Given this list of marker genes ERCC1, RTEL1, TINF2, SMC6, CCT3, ACTR8, PIF1 (PIF1 5'-to-3' DNA helicase), SLX1A, PINX1, ACTL6A, ATR, USP7, HSP90AA1, PARP3, ERCC4, CCT7, NSMCE2 (NCBI Gene Id 286053), PARN, PML, FBXO4, PRKCQ, SLX4, DCP2, PKIB, POT1, NAT10, NAF1, TCP1, XRCC5, INO80B, DKC1, YLPM1, HNRNPA1 (NCBI Gene Id 780920), YY1, MAPK15, NVL, DHX36, TFPT, SLF2, RUVBL1, SMC5, INO80C, NBN, STN1, EXOSC10, MYC, TERF2IP, UPF1, CTC1, HDAC8, HNRNPD (NCBI Gene Id 548), UCHL5 (NCBI Gene Id 82736), SMG6, LMNA, ATRX, CCT8, TENT4B, NEK2, TERF1, NSMCE3, TP53, XRCC1, CCT2, TNKS, SMG1, MAPK1, CCT6A, ATM, SRC, PPP1R10, MCRS1, CTNNB1, GNL3, ACD, HNRNPC, NFRKB, RAD50, SLX1B, NSMCE1, MAP3K4, AURKB, INO80E, HNRNPA2B1, ACTR5, TEN1, EID3, NABP2, INO80D, CCT5, PNKP, SMG5, SLF1, MRE11, MAP2K7 (NCBI Gene Id 5609), TNKS2, KLF4, TERF2, MAPKAPK5, PARP1, CCT4, NEK7, GNL3L, INO80, WRAP53, NSMCE4A, PTGES3, HNRNPU, SIRT6 (sirtuin 6), XRN1, MAPK3, RUVBL2, here is a description of the gene set: Human Gene Set: GOBP_REGULATION_OF_TELOMERE_MAINTENANCE Any process that modulates the frequency, rate or extent of a process that affects and monitors the activity of telomeric proteins and the length of telomeric DNA. species: Homo sapiens